Given this list of marker genes Clec7a, Tlr2, Nr4a1, Tlr6, Nlrc4, Tlr1, Cd209b, Parg (NCBI Gene Id 26430), Pglyrp4, Itgav, Nod1, Tlr9, Clec4n, Lbp, Trem2, Nod2, Tlr4, Ly96, Casp4, Naip2 (NLR family, apoptosis inhibitory protein 2), Pglyrp1, Naip5, Naip1, Scarb1, Naip6, Pglyrp3, Pglyrp2, Ssc5d, here is a description of the gene set: studied in species Mus musculus The series of events in which an external biotic stimulus is detected and converted into a molecular signal. An external biotic stimulus is defined as one caused or produced by a living organism other than the one being stimulated. Mouse Gene Set: GOBP_DETECTION_OF_EXTERNAL_BIOTIC_STIMULUS